The following is a description of a gene set: PtdIns(4,5)P2 in cytokinesis pathway species: Homo sapiens Human Gene Set: WP_PTDINS45P2_IN_CYTOKINESIS_PATHWAY, and this is the list of marker genes: EZR, OCRL, KIF23, RDX, RAB35, SEPTIN2, RACGAP1, MYL2, MSN, AFAP1, RHOA, ANLN